The following is a description of a gene set: studied in species Mus musculus This event has been computationally inferred from an event that has been demonstrated in another species.<p>The inference is based on the homology mapping from PANTHER. Briefly, reactions for which all involved PhysicalEntities (in input, output and catalyst) have a mapped orthologue/paralogue (for complexes at least 75% of components must have a mapping) are inferred to the other species. electronically inferred by orthology from the curated human pathway Reactome Pathway: TRKA activation by NGF part of: Activation of TRKA receptors, and this is the list of marker genes: Ngf